Given this list of marker genes MTREX, MPHOSPH6, EXOSC4, C1D, EXOSC6, ZCCHC8, TENT4A, ZCCHC7, YTHDC2, XRN2, ZFC3H1, DXO, PABPN1, RBM26, SRRT, EXOSC7, RBM7, RBM27, PAPOLG, EXOSC8, YTHDC1, ZC3H18, EXOSC2, EXOSC3, DIS3, EXOSC1, ZC3H4, EXOSC9, EXOSC5, ZC3H3, TENT4B, EXOSC10, NCBP2, WDR82, NCBP1, here is a description of the gene set: studied in species Homo sapiens Human Gene Set: REACTOME_NUCLEAR_RNA_DECAY Nuclear RNA decay